The following is a description of a gene set: Human Gene Set: MIR3120_3P Genes predicted to be targets of miRBase v22 microRNA hsa-miR-3120-3p in miRDB v6.0 with MirTarget v4 prediction scores > 80 (high confidence targets). studied in species Homo sapiens from publication Chen Y, Wang X (PMID 31504780), and this is the list of marker genes: PAK2, PDE4B (phosphodiesterase 4B), HIC2, LYSMD2, RTF1, DCAF1, TBR1, PTPN11, TBPL1, SNX29, ABTB2, AAK1, ZNF706, TAF9B, CCNT2, MRPL44, KIF13A, RSBN1, FAM43A, SCAF4, ELFN1, FBXL3, UBE2K, SLC39A14, TGIF2, ENPP1, AUTS2, G3BP2, NUFIP2, CDK6, THAP12, RIC1, SPDYE3, TANC2, JPH1, GPATCH2L, EGFL8, TMEM60, ZFYVE28, TLR8, NDRG4, FAM174A, FOXN2, ETF1, RPA3, ASAH1, IPO5, EFR3A, ARIH1, NLK, BBX, FGF8, TMEM61, AFF1, UBE2I, PLEKHA3, NRCAM, EPG5, LRIT3, SH3PXD2A (SH3 and PX domains 2A), TMEM255A, KIF1B, EID1, HIF1A, PXYLP1, RSF1, PCDH19, OGFRL1, RAB2B, ZBTB43, BMP6, CEP97, CYP4Z1, MTMR4, CNTFR, ZDHHC17, NKX2-5, AKIRIN2, MIDEAS, CNKSR2 (NCBI Gene Id 22866), MRTFB, PDGFB, SLC16A1, DAGLA, GNB1, GSE1, ZNF546, DDA1, N4BP2, RNF166, MBNL1, RBX1, TCF7L2, HOMER1 (NCBI Gene Id 9456), CTNND2, GPD2, DICER1, ZNF662, ADGRL3, MEF2A, CEP20, C18orf32, UNC93A, STAG1, GPR180, RAB14, ZNF879, TUBE1, TUBB3, SPG21, CXCR4, AKAP1 (A-kinase anchoring protein 1), GYG1, SMG7 (NCBI Gene Id 9887), GAB1, DPH3 (diphthamide biosynthesis 3), EIF4E (eukaryotic translation initiation factor 4E), HTR2A, CEBPZ, PEG10, SLC5A1, MYNN, ETV5, ALKBH1, S100PBP, SCAI, CUL3, RBM12, SSH2, ADIPOR2, GLCE, SPTLC2, CROT, CA10, ARPC5, TARDBP, ASAH2B, POLQ, VAPB, PLEKHA8, NCK1, SRGAP3, PAF1, UNC5C, ATAD2B, USP37, APBB2, KIAA1143, ANK3, SYNJ2BP, EBAG9, RASA1, PTGDR2, MEI4, APC, PDK3, CFAP65, UGCG, IFT70B, PTBP3, DOCK8, IKZF2, VDAC1, USP9X, WDR26 (WD repeat domain 26), NRAS, CLDN12, MTMR9, TAT, GAB3, MYH9, SBNO1, KIAA1217, SRSF3, SCN8A, GPATCH8, ZNF704, ZC3H11A, ARID1B, ARL6IP1, ETV1, OLFM3, PDE1C, PLAG1, WEE1, STMN1, FOXD2, MED21, PRTG, ACKR4, OTUD1, ZBTB39 (zinc finger and BTB domain containing 39), SOCS7, SLBP, CNBP, ADAM23, VAPA, IAPP, SRSF2, CD2AP, STAT3, MCM3, IL12B, METTL8, SERPINE2, MEX3C, ZFP28, KIAA1549, KRIT1, GZF1, CAB39, ZC3H12C, ACAP2, SPAG9, KLHL13 (kelch like family member 13), ARHGAP20, GRIK3, SLC35F5 (NCBI Gene Id 80255), DOCK10 (NCBI Gene Id 9714), FBXO30, SMAD1, HS2ST1, COL12A1, EDRF1, TMEM9B (NCBI Gene Id 56674), GNAI3, WNK3, TTC39A, KAT6A, TRANK1, PRKAR2A, DNAJC6 (DnaJ heat shock protein family (Hsp40) member C6), GCSAML, MAF, SECISBP2L, C2CD6, SKIL, RBMS1, KRT86, PRKAG2, FEM1C, SYT3, USP14, PDPN (NCBI Gene Id 29912), IDS, SIKE1, PPM1K, PHF3, NEDD4L, BRD10, THBS2, EIF4EBP2, MMADHC, POU4F2, ZBTB10, SLC7A2, KIF21B, GTF2A1, CREBRF, RNMT, RBL2, PTPRJ, MSI2 (NCBI Gene Id 124540), ARRDC3, EPC1, TNRC6B, USP31, WASL, POTEM, SYNJ1, NAA50, SLFN13, TAOK1, ADNP (activity dependent neuroprotector homeobox), MARCHF5, CRIPT, ARFGEF1, ZFPM2, CLOCK, STK17A, IRAK4, MYO10, SUMO3, SLC30A4, HACD3, RNF32 (ring finger protein 32), CACNB2, SMARCAD1, ASXL3, PEX5L, GLI3, EPM2AIP1, SLC7A14 (solute carrier family 7 member 14), RPL17-C18orf32, INSIG2, ARF6, ZMYND19, CAPN7, TRIP12, COL6A5, GRIA4, ARF3, TRIB2, MAPK8, GDAP2, ZNF608, CTNNB1, CNIH4, FBXO45, WFDC12, NR3C1, FKBP1B, DCUN1D4, ERBIN, PPP4R1, RRAS, ENC1, MAP2, STXBP5, SLFN11, RALGPS1, ZC2HC1A, MDFI, NYAP2, CLTC, DPM1, TLE4, SYT15, PRKAR1A, LIN28A, ATL2, ANK2, ABCC5, CELF2, NPAT, NR2E1, TGDS, PEAK1, SURF4, CENPQ, SORBS1, BAZ1A, ZNF142, TGFB2, ZNF620, KMT5B